Given this list of marker genes TUBAL3, CCT7, TUBA3E, TUBA8, CCT6A, TUBA1A (tubulin alpha 1a), TUBA1B, CCT4, CCT3, TUBB4B, CCT5, TUBA3D, TUBA1C, TCP1, TUBB6, TUBB1, TUBB4A, CCT6B (chaperonin containing TCP1 subunit 6B), TUBA4B (NCBI Gene Id 80086), TUBB2A, CCT8, TUBA3C, TUBA4A, TUBB2B, TUBB3, CCT2, here is a description of the gene set: Formation of tubulin folding intermediates by CCT/TriC Human Gene Set: REACTOME_FORMATION_OF_TUBULIN_FOLDING_INTERMEDIATES_BY_CCT_TRIC species: Homo sapiens